The following is a description of a gene set: Human Gene Set: HP_EVERTED_UPPER_LIP_VERMILION Inner aspect of the upper lip vermilion (normally apposing the teeth) visible in a frontal view, i.e., the presence of an everted upper lip. studied in species Homo sapiens Everted upper lip vermilion, and this is the list of marker genes: SETD1A, EDA2R, TCF3, POGZ, AP4E1, SMARCA4, DIS3L2, EDAR, EPG5, GBA1, RAI1, H4C9, CREBBP, AP4M1, WDR26, AP4S1, KIF7, EDA, KCNK4, AP4B1, MAP1B, NAA10, EDARADD, KCNH1, DNMT3A